The following is a description of a gene set: Genes with promoters bound by both PPARG and RXRA at 36 h time point of adipocyte differentiation of 3T3-L1 cells (preadipocyte). Control of cell differentiation occurs through transcriptional mechanisms and through epigenetic modification. Using a chromatin immunoprecipitation-on-chip approach, we performed a genome-wide search for target genes of peroxisome proliferator-activated receptor gamma (PPAR gamma) and its partner protein retinoid X receptor alpha during adipogenesis. We show that these two receptors target several genes that encode histone lysine methyltransferase SET domain proteins. The histone H4 Lys 20 (H4K20) monomethyltransferase PR-Set7/Setd8 gene is upregulated by PPAR gamma during adipogenesis, and the knockdown of PR-Set7/Setd8 suppressed adipogenesis. Intriguingly, monomethylated H4K20 (H4K20me1) levels are robustly increased toward the end of differentiation. PR-Set7/Setd8 positively regulates the expression of PPAR gamma and its targets through H4K20 monomethylation. Furthermore, the activation of PPAR gamma transcriptional activity leads to the induction of H4K20me1 modification of PPAR gamma and its targets and thereby promotes adipogenesis. We also show that PPAR gamma targets PPAR gamma2 and promotes its gene expression through H4K20 monomethylation. Our results connect transcriptional regulation and epigenetic chromatin modulation through H4K20 monomethylation during adipogenesis through a feedback loop. studied in species Mus musculus from publication Wakabayashi K, Okamura M, Tsutsumi S, Nishikawa NS, Tanaka T, Sakakibara I, Kitakami J, Ihara S, Hashimoto Y, Hamakubo T, Kodama T, Aburatani H, Sakai J (PMID 19414603) Human Gene Set: WAKABAYASHI_ADIPOGENESIS_PPARG_RXRA_BOUND_36HR, and this is the list of marker genes: GRPEL1, DNAJC19, PLA2G15, ACAA1, CELA1, YWHAG (NCBI Gene Id 96443), PTGR2, ITSN1, TOM1L2, HOXA3, DRC3, BTF3L4, SEC24C, PPP1R15B, CHP1, SCARB2, NATD1, PROC, ACOX1, EPHX2 (NCBI Gene Id 2053), MLST8, P3H4, PIM3, ELMOD2, GSK3A, ANKRD46, CRYZL1 (NCBI Gene Id 9946), PNRC1, SLC35E3, QTRT2, ACADS, ANKRD33, OTUD5, HCFC1R1, BFAR, ARC, FKBP10, LTBP3, UGT1A6, TPT1, CSNK1G2, HOXA1, MGST1, TXNIP, ARRDC2, SERPINE1, LIPE, TARBP2, ETFDH, HOXA4, CRTC2, NAA50, TXNDC12, IGSF6, IDH1, CAPN3, PXMP4, DLC1, HGH1, IBA57, VIM, SLC22A12, LMBRD1, GSG1, KLF11, CALHM6, ECI2, MICALL2, C2orf76, FILIP1L, ZNF486, SSPN, SF1, FAH, TTC41P, CCDC87, CPT2, DECR1, SPATC1, EXD1, RAMP1, SLCO1A2, PBX2, DLG4 (discs large MAGUK scaffold protein 4), HSP90B1, ACADVL, ZBTB2, KTI12 (NCBI Gene Id 112970), TRAF7, CCDC18, METTL9, GNAI2, ACADM, UCP2, IL15RA, BMP2K, SPAAR, ORC5, TMEM134, COQ3, RRP1B, PAN2, PSPC1, DBI, ST3GAL2, CBLB, ARF4 (ADP ribosylation factor 4), TMCC3, ECH1, NEGR1, UGT1A8, LMBR1, ETFB, HJURP, BCL2L13, FITM2, SETDB1, LPCAT3, THOC6 (NCBI Gene Id 79228), CMPK1, ATP6V1A, PITPNM1, POLD4, TMEM87A, RBM4B, CASP8, ILVBL, FNIP1, ZNF655, LPL, MAP3K12, PDE12, PLIN1, CPT1A, MYD88, ACAA2, MLF2, ELMOD3, MRPS33, NID1, NLRP4, HSDL2, ETFA, OXSR1, MMRN2, SNCG, TMED5, PEX11G, GANC, PCBP2, CMSS1